Given this list of marker genes NFE2L2, HES5, HES1, MYB, PCID2, MIXL1, N4BP2L2, DPF2, NOTCH1, TCF15, TMSB4X, HSPA9, GATA2, METTL14, here is a description of the gene set: species: Homo sapiens Human Gene Set: GOBP_NEGATIVE_REGULATION_OF_HEMATOPOIETIC_PROGENITOR_CELL_DIFFERENTIATION Any process that stops, prevents or reduces the frequency, rate or extent of hematopoietic progenitor cell differentiation.